The following is a description of a gene set: This event has been computationally inferred from an event that has been demonstrated in another species.<p>The inference is based on the homology mapping from PANTHER. Briefly, reactions for which all involved PhysicalEntities (in input, output and catalyst) have a mapped orthologue/paralogue (for complexes at least 75% of components must have a mapping) are inferred to the other species. part of: Sensory perception of taste Reactome Pathway: Sensory perception of sweet, bitter, and umami (glutamate) taste species: Mus musculus electronically inferred by orthology from the curated human pathway, and this is the list of marker genes: Tas2r118, Tas2r136, Tas2r144, Gnb3, Tas1r2, Tas2r108, Tas2r137, Tas2r139, Tas2r121, Tas2r107 (taste receptor, type 2, member 107), Tas1r3, Tas2r138, Tas2r105, Gnat3, Tas2r130, Tas2r119 (NCBI Gene Id 57254), Tas2r126, Tas2r120